The following is a description of a gene set: Genes predicted to be targets of miRBase v22 microRNA hsa-miR-6870-3p in miRDB v6.0 with MirTarget v4 prediction scores > 80 (high confidence targets). species: Homo sapiens Human Gene Set: MIR6870_3P from publication Chen Y, Wang X (PMID 31504780), and this is the list of marker genes: ZNRF1, KAT14, ATP1A4, FUT10, ZNF493, CPNE4, SOCS5, UBE2D3, TMEM87A, FTO, BLOC1S2, ANKRD34C, VNN1, MED13L, PRDM6, C1QTNF7, TFE3 (transcription factor binding to IGHM enhancer 3), MAP3K8, ITPA, KPTN, PLXNA2, PARP16, GCDH, WDR33, SCOC, MIS12, PSMA7, CCP110, OLIG3, SMR3B, TBX15, SLIT2, RILPL1, BTG1, GADD45A, RNF34, SYCP2, LSM2, ACAA1, CNKSR2, WAPL, TRABD2B, HYI (hydroxypyruvate isomerase (putative)), OPA1, COMMD9, DCAF17, DSCAM